Given this list of marker genes PLEKHG7, RBAK, TMEM132E, REEP3, ZFP62, PHACTR3, MRPL19, POU2F1, ANKS1A, MAP3K3, ZNF697, SPATA31C2, SUN1, FGD5, PRDM2, IER3IP1, PPM1H, MED14, CCDC47, PHF20, GBP2, CREM (NCBI Gene Id 1390), SEC14L2, CRK, COPS4, MFSD14B, ZBTB2, ABCC5, PROX1, ADCY9, ABCC4, SEMA4C, GUCY1A2, STXBP5L, ARHGAP5, ELOVL4, ZNF586, GPATCH2L, PRKCI, SNRNP40, TMCC2, EDN1, SLC24A2, CARNS1 (carnosine synthase 1, NCBI Gene Id 57571), BAK1, ADAM9, ZBTB37, UBE2G1, SNX18, TRIM71, ZNF518A, FAM234B, REL, PUM1, ESRRG, AGO4, CABYR, FOXN3, USP38, ELAVL4, PLEKHA8, SEMA4B, ZBTB43, UBR2, ENPEP, NRP2, CALCOCO2, AKAP1, SS18, DUS1L, NHLH2, DUSP6, VMA21, GPC1, ZCWPW2, RASAL2, EFCAB14, ABL2, PDE4DIP, OTX2, STARD13, TNFRSF1B, DTWD2, NCK2, CBFB, ABHD6, MAGEB2, STX6, KCNA1, SPATA31C1 (NCBI Gene Id 441452), CCDC126, RASGEF1A, DLGAP1, RFX5, FRAT1, CREB5, MKNK2, ATL2, PTGFRN, SMG9, SPSB4, CDS2, LPAR4, MAP3K1, SCN5A, PLEKHH1, ATP2B3, E2F7, ZSWIM6, CDH5, RYR2, ZNF704, FER, ZNF148, NRBF2, ARFGEF3, RRP15, ANAPC16, GRHL1, ZDHHC7, TET2, KIF1B, FAT4, ZNF236, ITCH, ZNF396, NR6A1, DOCK3, CBLL1, MARK1, FMR1, VPS37B, RPP14, TSPAN14, POLE, SCRT2, PRKRA, SLCO3A1, CMTR2, GRB10, TMEM9B, CECR2, IFT70B, TRIB2 (NCBI Gene Id 28951), CCDC169, KLF13, PI4K2B, PPP4R3A, SEL1L, FGFR2, CDK19, PIK3C2B, SH3TC2, TENT5A, MKNK1, RALGPS2, CCNC (NCBI Gene Id 892), XKR7, RBM20, CELSR2, ASXL3, MIER1, ATXN7, QPRT, TMEM135, RMND5A, LMLN, PPP2CA, DMC1, TRIM66, MAPDA, IPMK, PCDH7, ARID3A, SLC35A4, BEND6, ST18, RIT1, PEAK1, PGP, ENO4, RASSF3, LACC1 (laccase domain containing 1), CORO2B, PLAGL1, BRWD1, CER1, KCNK2, SLC10A6, PCNX1, RAPGEF5, COL4A1, BET1, UBR7, ATRX, HADHB, VPS4B, PLCB1, GXYLT1, QKI, DAZAP2, GCNT1, EHD2, IRF4, ZDHHC9, NIPAL4, ARNT2, FLG, FGF13, SYDE2, CTDSP2, NEDD9, AQP2 (aquaporin 2), SCARA5, ZKSCAN5, here is a description of the gene set: from publication Chen Y, Wang X (PMID 31504780) studied in species Homo sapiens Human Gene Set: MIR345_3P Genes predicted to be targets of miRBase v22 microRNA hsa-miR-345-3p in miRDB v6.0 with MirTarget v4 prediction scores > 80 (high confidence targets).